Given this list of marker genes PKDREJ (polycystin family receptor for egg jelly), COL11A1, PKD1L3, KCNQ1 (NCBI Gene Id 3784), REST, PIEZO1 (piezo type mechanosensitive ion channel component 1 (Er blood group)), PKD2L1, KCNK4, CHRNA9, HTR2A, WHRN, MKKS, PKD1L2, PHF24, TRPA1, HPN, KCNA1, NTRK1, PTPRQ, CXCL12, SERPINE2, SCN9A, SCN1A, TMC1 (NCBI Gene Id 53634), MYC, CHRNA10, ITGA2, PJVK, ADGRV1, LHFPL5, CAV3, TMC2, TTN, JUP, PKD1, KIT, TNF, TMEM120A, PECAM1, PTK2, CDH2, BACE1, ASIC2, SCN11A, TCAP, TMEM87A, ASIC3, PDZD7, PKD1L1, PKD2L2, CTNNB1, KCNK2, PIEZO2, PKD2, CSRP3, STRC, FYN, ANO3, here is a description of the gene set: species: Homo sapiens Human Gene Set: GOBP_DETECTION_OF_MECHANICAL_STIMULUS The series of events by which a mechanical stimulus is received and converted into a molecular signal.